The following is a description of a gene set: electronically inferred by orthology from the curated human pathway studied in species Mus musculus This event has been computationally inferred from an event that has been demonstrated in another species.<p>The inference is based on the homology mapping from PANTHER. Briefly, reactions for which all involved PhysicalEntities (in input, output and catalyst) have a mapped orthologue/paralogue (for complexes at least 75% of components must have a mapping) are inferred to the other species. part of: Signaling by PDGF Reactome Pathway: Downstream signal transduction, and this is the list of marker genes: Rasa1, Bcar1, Pik3cb, Pik3r2, Pdgfa, Hras, Stat5b, Pdgfrb, Crk, Grb2, Pdgfb, Stat5a (NCBI Gene Id 20850)